Given this list of marker genes COL9A2, NR2E3, COL18A1, PAK2, FZD4, COL2A1, COL11A2, TSPAN12, NDP, VCAN, CAPN5, COL11A1, KCNJ13, CRB1, CTNNB1, P3H2, BAP1, ZNF408, COL9A3 (NCBI Gene Id 1299), COL9A1, LRP5, ERBB3, here is a description of the gene set: Vitreoretinopathy Human Gene Set: HP_VITREORETINOPATHY studied in species Homo sapiens Ocular abnormality characterized by premature degeneration of the vitreous and the retina that may be associated with increased risk of retinal detachment.